Given this list of marker genes Ift122, Cdon, Phldb1, Tfap2a, Clasp2, Mab21l2, Zfp281, Nckap1, Gatad2a, Phldb2, Grem2, Clasp1, Fuz, Ofd1, Dag1, here is a description of the gene set: The process in which the anatomical structures of the embryonic soma are generated and organized. species: Mus musculus Mouse Gene Set: GOBP_EMBRYONIC_BODY_MORPHOGENESIS